Given this list of marker genes Fgf3, Fgf1, Fgf5, Fgf10, Fgf9, Grb2, Ptpn11, Frs2, Fgf23, Sos1, Fgf8, Kl, Fgf4, Frs3, Kras, Fgf2, Fgf20, Fgfr1, Fgf6, Fgf22, Fgf17, Hras, here is a description of the gene set: FRS-mediated FGFR1 signaling Mouse Gene Set: REACTOME_FRS_MEDIATED_FGFR1_SIGNALING species: Mus musculus